Given this list of marker genes CDK8, CDK19, MED12, CCNC, MED13, here is a description of the gene set: Human Gene Set: GOCC_CKM_COMPLEX species: Homo sapiens Cyclin-dependent kinase complex which reversibly associates with the Mediator complex. In Saccharomyces cerevisiae it consists of SSN2, SSN3, SSN8 and SRB8.